Given this list of marker genes PPM1A, HHAT, NMT2, PPM1B, HHATL, NMT1, here is a description of the gene set: species: Homo sapiens The covalent attachment of a lipid group to the amino terminus of a protein. Human Gene Set: GOBP_N_TERMINAL_PROTEIN_LIPIDATION